Given this list of marker genes Siah1b, Fis1 (fission, mitochondrial 1), Ptpn2, Bid, Flcn, Bok, Sh3glb1, Bub1, Eif2ak3, Cyct, Lck, Rps7, Clu, Siah1a, Myc, Msx1, Sfpq, Fbxw7, Nkx3-1, Rnf183, Knl1 (NCBI Gene Id 76464), S100a9, Serinc3 (serine incorporator 3), Ripk3, Gsdme, Vnn1, Bclaf1, Bmyc, Septin4, Rps3, Mtch2, Adcy10, Pias4, Steap3, Il19, Sirt1, Skil, Spop, Styxl1, Bax, Plscr1, Taf6, Trp53, Dnm1l, Rad9a, Nck2, Nupr1 (NCBI Gene Id 80556), Mcl1 (myeloid cell leukemia sequence 1), Park7, Prkra, Rack1, Nherf1, Nox1, Trp73, Becn1, Ubb, Bbc3, Ddit3, Mmp2, Sod1, Nck1, Plagl2, Nacc2, Il20ra, Bad, Cav1, Rpl26, S100a8, Pmaip1, Ei24, Fbh1, Bcl2l11, Bcap31, here is a description of the gene set: species: Mus musculus Mouse Gene Set: GOBP_POSITIVE_REGULATION_OF_INTRINSIC_APOPTOTIC_SIGNALING_PATHWAY Any process that activates or increases the frequency, rate or extent of intrinsic apoptotic signaling pathway.